Given this list of marker genes Hsp90aa1, Mtpap, Hsp90ab1, Dctpp1, P2ry6 (pyrimidinergic receptor P2Y, G-protein coupled, 6), Cad, Pola1, Dut, Nt5c, Ugp2, P2ry4, here is a description of the gene set: studied in species Mus musculus Mouse Gene Set: GOMF_PYRIMIDINE_NUCLEOTIDE_BINDING Binding to a pyrimidine nucleotide, a pyrimidine nucleoside esterified with (ortho)phosphate.